The following is a description of a gene set: Binding to phosphatidylinositol-3,4-bisphosphate, a derivative of phosphatidylinositol in which the inositol ring is phosphorylated at the 3' and 4' positions. studied in species Homo sapiens Human Gene Set: GOMF_PHOSPHATIDYLINOSITOL_3_4_BISPHOSPHATE_BINDING, and this is the list of marker genes: FCHSD2, COMMD1, ARAP3, PLEK2, PLEK, AKT1, HIP1R, GAB2, TTPA, PLEKHA4, ADAP2, MAPKAP1, PHLDA3, PLA2G4E, MYO1G, SH3PXD2A, RAG2, PLEKHA1, RS1, ZFYVE1, NCF1, ANXA8, PLEKHA2, DAPP1, HIP1, KIF16B, OBSCN (NCBI Gene Id 84033), SESTD1, WASHC2C